The following is a description of a gene set: Human Gene Set: REACTOME_CLEC7A_DECTIN_1_INDUCES_NFAT_ACTIVATION species: Homo sapiens CLEC7A (Dectin-1) induces NFAT activation, and this is the list of marker genes: CALM1, PPP3CB, PPP3R1, PPP3CA, NFATC3, ITPR1, NFATC2, AHCYL1, NFATC1, ITPR3, ITPR2